The following is a description of a gene set: Reactome Pathway: Defective BTD causes biotidinase deficiency part of: Defects in biotin (Btn) metabolism BTD deficiency is an autosomal recessive disorder in which the body is unable to recycle and reuse biotin (Btn). This results in a secondary Btn deficiency that leads to juvenile-onset multiple carboxylase deficiency (MIM:253260). Patients present with neurological and cutaneous symptoms, including seizures, hypotonia, skin rash, and alopecia, usually between the second and fifth months of life. Children with profound BTD deficiency are treated with pharmacological doses of biotin (5-20 mg daily). Neonatal screening for BTD deficiency is performed in most states of the United States and many other countries. studied in species Homo sapiens, and this is the list of marker genes: BTD